Given this list of marker genes Gpm6b, Pik3r1, Tek, Tsc1, Apod, Enpp2, Camsap3, Ldb1 (LIM domain binding 1), Wdpcp, Actg1, Fmn1, Grem1, Nrp1, Clasp1, Ptpra, Smad3, Rock1, Limch1, Hrg, Thy1, Col16a1, Clasp2, Ptk2, Iqsec1, Fermt2, Epb41l5, Dmtn, Ptprj, Wnt4, Mapre2, Abl1, Arhgap6, Rcc2, Lrp1, Epha3, Dapk3, Arf6, Lims1, S100a10, Coro1c, Efna5, Ppm1f, Phldb2, Itgb1bp1, Mmp14, Rac1, Iqgap1, Macf1, Vcl, Dusp22, Myh9, Ptpn11 (protein tyrosine phosphatase, non-receptor type 11), Dusp3, Sdc4, Map4k4 (NCBI Gene Id 98646), Dlc1, Peak1, Vegfa, Fam107a, Poldip2, Kdr, Cfl1, Rhod, Myoc, Acvrl1, Src, Lamtor2, Pten, Slk, here is a description of the gene set: species: Mus musculus Mouse Gene Set: GOBP_REGULATION_OF_CELL_SUBSTRATE_JUNCTION_ORGANIZATION Any process that modulates the frequency, rate or extent of cell-substrate junction organization.